Given this list of marker genes CCL3, SMR3A, PTGES, KCND2, ACP3, GRIN2A, NTRK1, CHRNB2, NLGN2, ITGA2, PENK, SPX, MMP24, PRDM12, MAPK3 (NCBI Gene Id 5595), TMEM100, COMT, HOXD1, AQP1, OPRL1, KCNK4, GIP, CXCL12, NMU, PROK2, MME, OPRM1, NPY1R, CCR2, TAC1, CHRNA4, MRGPRX2, ADORA1, PIRT, RETREG1, TMEM120A (transmembrane protein 120A), SCN9A, PHF24 (PHD finger protein 24), ALOXE3, NIPSNAP1, TAFA4, HOXB8, SCN11A, LXN, ANO1, P2RX4, ASIC3, ATPSCKMT, NR2F6, ABCB1, GPR171, EPHB1, MC1R, MECP2, FABP5, SMR3B, GRIN2D, SCRN3, PNOC, DISC1, HTR2A, TAC4, TRPA1, BACE1, KCNA2, CDK5, KCNA1, OPRPN, GRM1, ZFHX2, CCL2, NDN, CCN3, POMK, MGLL (monoglyceride lipase), OPRK1, TRPV1, P2RX7, NGF, FYN, IAPP, TNF, NTSR1, SCN1A, here is a description of the gene set: species: Homo sapiens Human Gene Set: GOBP_SENSORY_PERCEPTION_OF_PAIN The series of events required for an organism to receive a painful stimulus, convert it to a molecular signal, and recognize and characterize the signal. A painful stimulus is any physical or chemical event that has the potential to cause tissue damage (actual or perceived) and activates the nociceptive system.